The following is a description of a gene set: Longitudinal, linear prominences in the fingernail plate. Human Gene Set: HP_RIDGED_FINGERNAIL studied in species Homo sapiens Ridged fingernail, and this is the list of marker genes: TINF2, DVL3, WNT5A, EFNB1, DVL1, MSX1, IKBKG, FZD2, SLC39A4